The following is a description of a gene set: Histone methyltransferases catalyze site-specific deposition of methyl groups, enabling recruitment of transcriptional regulators. In mammals, trimethylation of lysine 4 in histone H3, a modification localized at the transcription start sites of active genes, is catalyzed by six enzymes (SET1a and SET1b, MLL1–MLL4) whose specific functions are largely unknown. By using a genomic approach, we found that in macrophages, MLL4 (also known as Wbp7) was required for the expression of Pigp, an essential component of the GPI-GlcNAc transferase, the enzyme catalyzing the first step of glycosylphosphatidylinositol (GPI) anchor synthesis. Impaired Pigp expression in Wbp7-/- macrophages abolished GPI anchor-dependent loading of proteins on the cell membrane. Consistently, loss of GPI-anchored CD14, the coreceptor for lipopolysaccharide (LPS) and other bacterial molecules, markedly attenuated LPS-triggered intracellular signals and gene expression changes. These data link a histone-modifying enzyme to a biosynthetic pathway and indicate a specialized biological role for Wbp7 in macrophage function and antimicrobial response. Human Gene Set: GSE30971_2H_VS_4H_LPS_STIM_MACROPHAGE_WBP7_HET_DN Genes down-regulated in bone marrow-derived macrophages with heterozygous MLL4 knockout: 2h LPS versus 4h LPS. from publication Austenaa L, Barozzi I, Chronowska A, Termanini A, Ostuni R, Prosperini E, Stewart AF, Testa G, Natoli G (PMID 22483804) studied in species Homo sapiens, and this is the list of marker genes: CDKN2B, SIGLEC15, KIF9, CHI3L2 (NCBI Gene Id 9155), TNFRSF21, KCNAB1, PNPLA8, ELOVL7, ZIM3, MYOT, ZXDA, ESRRG, ADCY10, GADD45B, ENSG00000223438, LONRF2, ILDR2, MYDGF, CXCL2, LINC02537, AFAP1-AS1, EFNB2, NEUROD6, PRRC2C, PLAT, DNAJB9, MGAT2, LINC01139, ZNF214, LINC01093, CA10, FERMT2, MINDY3, FCGR1A, CCL20, HSD3B1, SAP30BP, NKX3-1, IQCM, AGO2, PDGFRA, TLE1, XBP1 (X-box binding protein 1), CGRRF1, STK26, OAZ3, LAMA2, RBM7, PLAC8, CDKN2A, C4orf17, PTGS2, ATXN3L, HS2ST1, PRH1, GOLGA5, ZNF705G, EPM2AIP1, SIGLEC6, CTSLP8, ELAPOR1, SOCS3, PLEKHA6, C11orf40, POU2F3, NEURL1B, OTX2, HOTTIP, GRHL1, TXLNB, KCNK2, STEAP1, HOXB-AS3, SLC14A2, CEACAM3, FBXO39, LCOR, CTHRC1, SH3GLB1, NDP, CNNM1, PCA3, FBN1, NEDD4, AADACL2, EMP2, TM4SF1, HAGLR, TACR3, LDHAL6A, GFPT2, TRAF3IP2, HORMAD2, TEX15 (NCBI Gene Id 56154), KCNJ5-AS1, FSD1L, MSH4, NFAT5, FGF13, ADGRG2, IFNA16, TVP23B, PPP1R3A, CLGN, ZKSCAN5, C18orf21, SFR1, H2AC16, MARCHF3, RGN, FLT1, CYP7B1, SLAMF1, ELL2, MTPN, MYO5B, LINC02026, ARHGAP24, SMOC2, CHL1-AS2, ANKRD30BP2, IGHV3OR16-13, GJC1, ABTB2, GPA33, SCOC-AS1, NME5, ZBTB38, ERVMER34-1, KRTAP4-2, SPMIP3, TP53BP2, CAPN5, GNG2, BTNL8, NUDT21, IL23A (NCBI Gene Id 51561), ACOT12, ANKRD55, MIR155HG, CCDC198, MAP3K4, PRKAA2, RPGRIP1, PDE4B, OLFM3, GDF11, C11orf96, LRP11 (NCBI Gene Id 84918), CSF2, STKLD1, RBM17, SH3GL1P2, HCAR3, SERPINB7, LINC02092, STAT3, DCAF4L2, NYNRIN, C12orf54, MS4A5, IL36G, NCR1, LIX1, SYPL2, MCC, OR10A5, GADD45A, DGKI (diacylglycerol kinase iota), MAP3K20, RALGAPA1, SYNDIG1L, KRT23, OR8D1 (NCBI Gene Id 283159), DPH3P1, NEK11, LINC00698, BCL2A1, SLC25A45, KANK1, KAZN, C1orf87, TTC29, ZBTB10, MED14, UGT2B15, PRRC1, OSTCP1, STRIP2, LINC00410, ZNF295-AS1, BAALC, SH2D4B